Given this list of marker genes TRMT61B, TRMT61A, NSUN6, LCMT2, TARBP1, TRMT5, TRMT44, NSUN3, TRDMT1, TRMT2B, TRMT10C, TRMT2A, METTL2B, TRMT9B, TRMT11 (tRNA methyltransferase 11 homolog), TRMT10A, BCDIN3D, THUMPD3, TRMO, METTL2A, ALKBH8, TRMT1, TRMT13, TYW3, METTL6, TRMT10B, METTL8, METTL1, NSUN2, TRMT1L, THUMPD2, FTSJ1, TRMT12, here is a description of the gene set: Catalysis of the transfer of a methyl group from a donor to a nucleoside residue in a tRNA molecule. studied in species Homo sapiens Human Gene Set: GOMF_TRNA_METHYLTRANSFERASE_ACTIVITY